The following is a description of a gene set: Paroxysmal, recurrent episodes of vomiting. Episodic vomiting Human Gene Set: HP_EPISODIC_VOMITING species: Homo sapiens, and this is the list of marker genes: NDUFS7 (NCBI Gene Id 4727), NOTCH2NLC, MT-TQ, UNC45A, HMGCL, ACADVL, MT-CO2, MT-TK, MT-TW, PDCD10, CDK13, CPOX, SHANK3, NSD1, NLRC4, OTC, FAH, CDK8, KRIT1, MT-ND6, ZEB2, PIK3CA, MT-TL1, ADNP, FGF13, HS3ST6, MT-CO1, MT-ND4, ALDH18A1, GAMT, MPV17, MT-ND1, SEC61A1, HNRNPK, ALAD, RNH1, NEXMIF, MT-TV, NFIX, SUOX, NDUFS1, CDC42BPB, MT-CYB, NAXD, SLC25A15, MT-TF, MT-ND5, UQCRC2, GK, MT-ND2, CCM2, POGZ, LBX1, MT-TC, TTR, MT-ATP6, CA5A, COQ2, SLC5A6, MT-TS2, ALG11, MT-ND3, ARG1, MT-CO3, D2HGDH